The following is a description of a gene set: species: Mus musculus from publication Johansson FK, Göransson H, Westermark B (PMID 15750623) Retroviral tagging previously identified putative cancer-causing genes in a mouse brain tumor model where a recombinant Moloney murine leukemia virus encoding the platelet-derived growth factor B-chain (MMLV/PDGFB) was intracerebrally injected in newborn mice. In the present study, expression analysis using cDNA arrays revealed several similarities of virus-induced mouse gliomas with human brain tumors. Brain tumors with short latency contained on average 8.0 retroviral insertions and resembled human glioblastoma multiforme (GBM) whereas long-latency gliomas were of lower grade, similar to human oligodendroglioma (OD) and had 2.3 insertions per tumor. Several known and novel genes of tumor progression or cell markers were differentially expressed between OD- and GBM-like tumors. Array and quantitative real-time PCR analysis demonstrated elevated expression similar to Pdgfralpha of retrovirally tagged genes Abhd2, Ddr1, Fos, Ng2, Ppfibp1, Rad51b and Sulf2 in both glioma types compared to neonatal and adult normal brain. The retrovirally tagged genes Plekhb1, Prex1, Prkg2, Sox10 and 1200004M23Rik were upregulated in the tumors but had a different expression profile than Pdgfralpha whereas Rap1gap, Gli1, Neurl and Camk2b were downregulated in the tumors. The present study accentuates the proposed role of the retrovirally tagged genes in PDGF-driven gliomagenesis and indicates that insertional mutagenesis can promote glioma progression. Human Gene Set: JOHANSSON_BRAIN_CANCER_EARLY_VS_LATE_DN Genes down-regulated in early vs late brain tumors induced by retroviral delivery of PDGFB., and this is the list of marker genes: DCN, SPARC, MAT2B, CST3, NDN, SELENOP, CAMK2G, TEF, ATP2A2, GJA1, CHN1, ACOT7, PLEKHB2, QDPR, CLU (clusterin), IGFBP5, NCDN, ATP1B1, IGFBP4, CALM1, HDAC11, SPARCL1, GNAS, GSTM5, NDRG1, PLA2G7, CTSD, ITM2B, GHITM, CRYAB (NCBI Gene Id 1410), ACSBG1, CLSTN1, PFKM, NDRG2, CSDC2, LRP1, C3, PYGB, GRINA, NSF, MMD2, CALY, ALDOC